Given this list of marker genes Otud6b, Adrm1b, Psmd11, Psmd10, Ublcp1, Psmg1, Sem1, Psmg3, Psmg4, Pomp, Ecpas, Psmd9, Psmd5, Elp2, Adrm1, Psmg2, here is a description of the gene set: The aggregation, arrangement and bonding together of a mature, active proteasome complex. Mouse Gene Set: GOBP_PROTEASOME_ASSEMBLY studied in species Mus musculus